The following is a description of a gene set: Reactome Pathway: MET activates STAT3 electronically inferred by orthology from the curated human pathway This event has been computationally inferred from an event that has been demonstrated in another species.<p>The inference is based on the homology mapping from PANTHER. Briefly, reactions for which all involved PhysicalEntities (in input, output and catalyst) have a mapped orthologue/paralogue (for complexes at least 75% of components must have a mapping) are inferred to the other species. species: Mus musculus part of: Signaling by MET, and this is the list of marker genes: Hgf